The following is a description of a gene set: Mouse Gene Set: GOBP_REGULATION_OF_REMOVAL_OF_SUPEROXIDE_RADICALS species: Mus musculus Any process that modulates the frequency, rate or extent of removal of superoxide radicals., and this is the list of marker genes: Fbln5, Gch1, Dhfr, Nfe2l2, Cd36